The following is a description of a gene set: Hedgehog is a secreted morphogen that has evolutionarily conserved roles in body organization by regulating the activity of the Ci/Gli transcription factor family. In Drosophila in the absence of Hh signaling, full-length Ci is partially degraded by the proteasome to generate a truncated repressor form that translocates to the nucleus to represses Hh-responsive genes. Binding of Hh ligand to the Patched (PTC) receptor allows the 7-pass transmembrane protein Smoothened (SMO) to be activated in an unknown manner, disrupting the partial proteolysis of Ci and allowing the full length activator form to accumulate. <br>While many of the core components of Hh signaling are conserved from flies to humans, the pathways do show points of significant divergence. Notably, the human genome encodes three Ci homologues, GLI1, 2 and 3 that each play slightly different roles in regulating Hh responsive genes. GLI3 is the primary repressor of Hh signaling in vertebrates, and is converted to the truncated GLI3R repressor form in the absence of Hh. GLI2 is a potent activator of transcription in the presence of Hh but contributes only minimally to the repression function. While a minor fraction of GLI2 protein is processed into the repressor form in the absence of Hh, the majority is either fully degraded by the proteasome or sequestered in the full-length form in the cytosol by protein-protein interactions. GLI1 lacks the repression domain and appears to be an obligate transcriptional activator.<br> Vertebrate but not fly Hh signaling also depends on the movement of pathway components through the primary cilium. The primary cilium is a non-motile microtubule based structure whose construction and maintenance depends on intraflagellar transport (IFT). Anterograde IFT moves molecules from the ciliary base along the axoneme to the ciliary tip in a manner that requires the microtubule-plus-end directed kinesin KIF3 motor complex and the IFT-B protein complex, while retrograde IFT back to the ciliary base depends on the minus-end directed dynein motor and the IFT-A complex. Genetic screens have identified a number of cilia-related proteins that are required both to maintain Hh in the 'off' state and to transduce the signal when the pathway is activated. studied in species Homo sapiens Reactome Pathway: Hedgehog 'on' state part of: Signaling by Hedgehog, and this is the list of marker genes: RPS27A (NCBI Gene Id 6233), PTCH1, KIF3A, DRC4, PSMD6, PSMB2, PSMB6, SPOP, PSMB5, PSMB4, PSMD1, BOC, CUL3, PSMD13, PSMA4, ARRB1, PSMD7, CDON (cell adhesion associated, oncogene regulated), GRK2, PSMB7, EVC, PTCH2, SUFU, IQCE, PSMD11, PSMA5, SMURF2, SMO, PSMC6, GLI3, GLI1, GPR161, PSMA7, NUMB, PSMC5, PSMD8, PSMB1, KIF7, PSMC3, PSMC4, UBB, HHIP, DHH, CDC73, DZIP1, SMURF1, EFCAB7, PSMD3, RBX1, IHH, UBC, PSMD2, ADRM1, GAS1, EVC2, PSMC1, PSMA1, ULK3, ARRB2, PSMD12, PSMA6, PSMC2, PSMD14, ITCH, PSMA3, PSMB3, PSMA2, SPOPL, UBA52, GLI2, SEM1, CSNK1A1, SHH